The following is a description of a gene set: Mouse Gene Set: GOBP_SPINAL_CORD_OLIGODENDROCYTE_CELL_DIFFERENTIATION studied in species Mus musculus The process in which neuroepithelial cells in the neural tube acquire specialized structural and/or functional features of oligodendrocytes. Oligodendrocytes are non-neuronal cells. The primary function of oligodendrocytes is the myelination of nerve axons in the central nervous system. Differentiation includes the processes involved in commitment of a cell to a specific fate., and this is the list of marker genes: Sox13, Nkx2-2, Olig2, Ascl1, Sox6